Given this list of marker genes TIMP2, EPB41L2, WARS1, ACTN1, PXDN, ITGA9, DUSP5, FRMD8, IFI27 (NCBI Gene Id 3429), BHLHE40, ADGRF5, BAIAP2, MARCKS, PRICKLE2, KDR, S1PR1 (NCBI Gene Id 51546), ARHGEF7, LYVE1, USP13, DAAM1, PELI1, MAP1B, TMOD3, GRB10, BST2, GALNT1, OSMR, GALNT15, TMEM44, PCGF2, ERG (ETS transcription factor ERG), MID1 (midline 1), STC1, UPP1, ITGA5, SMAD6, DYNC2I1, CEMIP2, SNRK, CLEC14A, PLPP3, CRHBP (corticotropin releasing hormone binding protein), SLC7A8, PTPRB, NR2F1, CAPZA2, SPARC, BSDC1, PPFIBP1, RHOJ, FGFR1, DENND4C, UACA, JUND, F8, HSP90B1, TSPAN7, IL1R1, SLC2A3, PTPN1, CCL15-CCL14, PRSS23, MCF2L, TIMP3, CCL14, NR2F2, COL4A1, CDH5, ECM1, MEG3, FSCN1, PEA15, UGCG, ADAMTS9, LIMA1, SHANK3, TCF7L1, LIMCH1, CLEC1B, GNG11, HIC1, EPAS1, TSPAN18, FCN2, DLC1, PXN, ECE1, IFI44L, AHCTF1, MARCKSL1, HERC1 (NCBI Gene Id 8925), RDX, PHACTR2, ARGLU1, SPRY1, NRP2, TRIOBP, RBMS1, PRKAR1A, CTSL, MYADM, CTSD, MRC1, PLTP, PLXNA2, CUL4B, PHC2, TFPI, TOP1, ASAP1, RAPGEF5, DNASE1L3, EHD3, FGF23, CCDC50, C1QTNF1, LIFR, WWTR1, CNTNAP3B, FLT1, ENG, STAB1, NOSTRIN, FKBP1A, MS4A6A, EDN1, ST6GALNAC3, AFF1, SREK1, SNX5, CAVIN2, RELN, CLEC4M, EGFL7, FILIP1, SPRY4, CEP170, GATA4, FXYD6, NISCH, FCHSD2, CLEC4G, ZNF160, MYCT1, SOCS3, SEC14L1, CDC37, YES1, MRO, TNFRSF10B, PDGFB, TM4SF1, COL4A2, IL4R, TGM2, PIEZO2, LUZP1, F2R, NUAK1, CNN3, MCAM, ADAMTS4, NRP1, STAB2, NCOA7, RRBP1, MEF2C, NTN4, DOCK9, MYO6 (NCBI Gene Id 4646), ANKS1A, MACF1, OIT3, KDM6B, WSB1, TIE1, PRCP, ADGRL2, EPOR (NCBI Gene Id 2057), SRPX, CDH13 (cadherin 13), ARHGAP29, SLC27A3, GOLGB1, PHF10, RASAL2, HIF1A (NCBI Gene Id 3091), NPDC1, FCN3, KLF7, GBP4, PRKD3, FCGRT, HYAL2, IL33, PREX2, CHD7 (NCBI Gene Id 780907), FAM107A, ZEB1, IL1RL1, FLT4, CAVIN1, IL6ST, EFNB2, CD4, TPM4, LGMN, ROBO4, TOX2, MMRN1, SEMA6A, ARHGAP26, FZD4, MYO10, C11orf96, ACKR3, APP, DDX21, DUSP6, HES1, TUBB6, CD36, MYH10, HPCAL1 (NCBI Gene Id 96763), APOLD1, HIPK2, VASH1, ADM, SERPINH1, ESAM, EIF4G3, TAL1, ZNF462, ANGPTL4, PDE2A, NPR1, ADGRL4, SMTN, NR5A2, ZNF451, NOTCH4, TCIM, FLNB, NOVA2, COL6A2, FOSL2, PARP14 (poly(ADP-ribose) polymerase family member 14), BNIP3L, TGFBR3, FHL1, KCTD20 (NCBI Gene Id 222658), MAF, JMJD1C, BTNL9, ME2, TANC1, PLK2, NASP, PPP1R15A, SDCBP, MAP7D3, YBX3, ANKRD11, TP53I11, C5AR2, INSR, PDLIM1, EMP1, TCF4 (transcription factor 4), ABCG1, CD93, AKAP12, NID1, TINAGL1, PLEKHG1, TFPI2, AFF4, CD14, SLC25A37 (NCBI Gene Id 55881), IGFBP7, NOS3, SOX7, MTCL2, S100A16, ANGPT2, ITPRIP, SASH1, TACC1, GARRE1, CALU, RPGR, CRIM1, TCF7L2, CXCL16, IFITM10, LDB2, RASIP1, CDC42BPB, TIMP1, PCDH17, MAP3K6, FAM43A, SGK1, EXOC3L2, here is a description of the gene set: from publication Aizarani N, Saviano A, Sagar, Mailly L, Durand S, Herman JS, Pessaux P, Baumert TF, Grün D (PMID 31292543) studied in species Homo sapiens Human Gene Set: AIZARANI_LIVER_C9_LSECS_1